Given this list of marker genes Ednrb, Shh, Drd4, Vip, P2ry2, Ar, Oxtr, Oxt, Cnr1, Acvr2a, Ada, P2ry1, here is a description of the gene set: The hardening, enlarging and rising of the penis which often occurs in the sexually aroused male and enables sexual intercourse. Achieved by increased inflow of blood into the vessels of erectile tissue, and decreased outflow. Mouse Gene Set: GOBP_PENILE_ERECTION studied in species Mus musculus